The following is a description of a gene set: studied in species Homo sapiens Human Gene Set: HP_ALLERGY Allergy An allergy is an immune response or reaction to substances that are usually not harmful., and this is the list of marker genes: MTOR, JAK1, DPP9, IGHG2, CPN1, SLC19A1, PLCG2, SMAD2, FOCAD, CSTA, IL6ST, CDSN (corneodesmosin), STAT6, CARD11, PGM3, CHD1, CTLA4, TGM5, SIK3, CARMIL2, ABCC9, FOXP3, SOX6, SPTBN1, BBS1, PSTPIP1 (NCBI Gene Id 9250), IPO8, FOXP1, POLD3, ARL6, SLC27A4, SPINK5, DOCK8, CAMK2B, RBM8A, KRT74, DSG1, CCDC28B, IGKC, COX4I2, ADA, CRELD1